The following is a description of a gene set: Mouse Gene Set: GOBP_POSITIVE_REGULATION_OF_SMOOTH_MUSCLE_CELL_CHEMOTAXIS Any process that activates or increases the frequency, rate, or extent of smooth muscle cell chemotaxis. species: Mus musculus, and this is the list of marker genes: Lpar1, Nrp1, Pdgfd, Mdk, Aif1